The following is a description of a gene set: species: Homo sapiens Exercise-induced muscle stiffness A type of muscle stiffness that occurs following physical exertion. Human Gene Set: HP_EXERCISE_INDUCED_MUSCLE_STIFFNESS, and this is the list of marker genes: PFKM (phosphofructokinase, muscle), PYGM, MLIP, SLC16A1, ATP2A1 (NCBI Gene Id 487), SCN4A, PHKA1, CAV3